Given this list of marker genes CYTH2, RNASEL (ribonuclease L), ALDH1A2, SLC25A40, RTN3, GAPDH, IL1RN (NCBI Gene Id 3557), SLAMF1, POLR3K, ADGRB3, CD180, HIRIP3, MT2A, AURKA, CD1B, ALAS1, LGALS2, FANCG (NCBI Gene Id 82603), CCND2, QPCT, IFNG, here is a description of the gene set: from publication García-Piñeres AJ, Hildesheim A, Dodd L, Kemp TJ, Yang J, Fullmer B, Harro C, Lowy DR, Lempicki RA, Pinto LA (PMID 19155521) Human papillomavirus (HPV) virus-like particle (VLP) vaccines were recently licensed. Although neutralizing Ab titers are thought to be the main effectors of protection against infection, early predictors of long-term efficacy are not yet defined and a comprehensive understanding of innate and adaptive immune responses to vaccination is still lacking. Here, microarrays were used to compare the gene expression signature in HPV-16 L1 VLP-stimulated PBMCs from 17 vaccine and 4 placebo recipients before vaccination and 1 mo after receiving the second immunization. Vaccination with a monovalent HPV-16 L1 VLP vaccine was associated with modulation of genes involved in the inflammatory/defense response, cytokine, IFN, and cell cycle pathways in VLP-stimulated PBMCs. Additionally, there was up-regulation of probesets associated with cytotoxic (GZMB, TNFSF10) and regulatory (INDO, CTLA4) activities. The strongest correlations with neutralizing Ab titers were found for cyclin D2 (CCND2) and galectin (LGALS2). Twenty-two differentially expressed probesets were selected for confirmation by RT-PCR in an independent sample set. Agreement with microarray data was seen for more than two-thirds of these probesets. Up-regulation of immune/defense response genes by HPV-16 L1 VLP, in particular, IFN-induced genes, was observed in PBMCs collected before vaccination, with many of these genes being further induced following vaccination. In conclusion, we identified important innate and adaptive response-related genes induced by vaccination with HPV-16 L1 VLP. Further studies are needed to identify gene expression signatures of immunogenicity and long-term protection with potential utility in prediction of long-term HPV vaccination outcomes in clinical trials. species: Homo sapiens Human Gene Set: GARCIA_PINERES_PBMC_HPV_16_L1_VLP_AGE_18_25YO_12MO_CORRELATED_WITH_ANTIBODY_RESPONSE_POSITIVE Genes positively correlated with antibody response in peripheral blood mononuclear cell in young adults (18-25) after exposure to HPV-16 L1 VLP, time point 12M. Comment: Spearman Correlation of Gene Expression with Neutralizing Antibody Levels